Given this list of marker genes Gtf2a1, Cebpa, Med31, Med27, Med14, Med30, Taf4b, Jun, Med13, Taf11, Nkx2-5, Cand1, Hnf1b, Taf10, Bclaf1, Med21, Kat8, Med11, Srf, Med18, Med20, Trp53, Sub1, Med1, Twist1, Taf4, Mitf, Wnt10b, Med23, Taf2, Pou5f1, Dhx36, Med16, Ercc6, Setx, Fosl1, Gtf2a2, Med9, Med28, Paxip1, Med4, Xpa, Med8, Taf3, Med15, Med17, Taf6, Znhit1, Taf13, Psmc6, Med29, Med6, Med12 (NCBI Gene Id 59024), Tbp, Ahr, Nfkb1, Med24, Taf9, Taf8, Hnf1a, Myc, Med26, Ercc1, Creb1, Nfkbia, Med19, Ikzf1, Taf5, Med22, Taf1, Taf12, Taf7, Med10, Med25, Med7, here is a description of the gene set: Any process that activates or increases the frequency, rate or extent of DNA-templated transcription initiation. species: Mus musculus Mouse Gene Set: GOBP_POSITIVE_REGULATION_OF_DNA_TEMPLATED_TRANSCRIPTION_INITIATION